Given this list of marker genes BLM, TMEM97, POP7, TUBB4B, DIO2, SPC25, PTPRF, CCNE1, IL7R, EXOSC8, MYBL1, SLC7A1, MELK, LPXN, PALM2AKAP2, POLR1E (RNA polymerase I subunit E), OGFRL1, CENPU, GINS2, FOXM1, MEST, THBS1, EFEMP1, CDC6, NRG1, EIF5, RAD54B, MCM4, RGS20, FAM111A, GPRC5A, P3H2, POLR3K, RFC4, ZWINT, OLR1, AMIGO2, CKS2, MT1X, AURKB, MAD2L1, CD44, ATAD2, MCM3, YWHAH, FST, CALM2, CCNE2, RRP7A, CD24, MYOF, DDAH1, EIF2S1, ZWILCH, DHFR, TIPIN (TIMELESS interacting protein), PRIM1, FHL2, CCDC86, CDC45 (NCBI Gene Id 8319), MCM7, MCM6, ORC1, DCTPP1, PBK, BIRC5, DNAJC9, SERPINB2, UGCG, SLC38A1, CDC42EP3, PNP, SLC7A5, GINS3, HJURP, TMPO, MCM5, FOSL1, MRTO4, CAV2, TRIP13, RAD54L, TPM1, OIP5, FANCI, SERPINE2, PEA15, RRAS2, MICAL2, RFTN1, PDSS1, ODC1, NXN, H2AX, TNFRSF12A, ITGBL1, AUNIP, CCNA2, E2F1, NCAPG2, GINS1, RFWD3, DKK1, GMNN, TNPO1, PLAU (NCBI Gene Id 95176), EXO1, PFKP, NAV3, CTPS1, BARD1, DTL, RAD51AP1, DKC1 (dyskerin pseudouridine synthase 1), LYPD1, DMD, FEN1, TMEM158, ASF1B, RRM2, UBE2C, PRPS1, TYMS, SHCBP1, CDC25A (cell division cycle 25A), MCM2, MCM10, STC2, E2F8, MET, KIF2C, CXCL8, DSCC1, USP1, TUBB6, SPDL1, CAV1, EGFR, ABHD5, CDK1, SH3BP4, NMT2, CRIM1, here is a description of the gene set: Human Gene Set: RUIZ_TNC_TARGETS_DN Genes down-regulated in T98G cells (glioblastoma) by TNC. from publication Ruiz C, Huang W, Hegi ME, Lange K, Hamou MF, Fluri E, Oakeley EJ, Chiquet-Ehrismann R, Orend G (PMID 15492259) species: Homo sapiens Tenascin-C is an adhesion-modulating extracellular matrix molecule that is highly expressed in tumor stroma and stimulates tumor cell proliferation. Adhesion of T98G glioblastoma cells to a fibronectin substratum is inhibited by tenascin-C. To address the mechanism of action, we performed a RNA expression analysis of T89G cells grown in the presence or absence of tenascin-C and found that tenascin-C down-regulates tropomyosin-1. Upon overexpression of tropomyosin-1, cell spreading on a fibronectin/tenascin-C substratum was restored, indicating that tenascin-C destabilizes actin stress fibers through down-regulation of tropomyosin-1. Tenascin-C also increased the expression of the endothelin receptor type A and stimulated the corresponding mitogen-activated protein kinase signaling pathway, which triggers extracellular signal-regulated kinase 1/2 phosphorylation and c-Fos expression. Tenascin-C additionally caused down-regulation of the Wnt inhibitor Dickkopf 1. In consequence, Wnt signaling was enhanced through stabilization of beta-catenin and stimulated the expression of the beta-catenin target Id2. Finally, our in vivo data derived from astrocytoma tissue arrays link increased tenascin-C and Id2 expression with high malignancy. Because increased endothelin and Wnt signaling, as well as reduced tropomyosin-1 expression, are closely linked to transformation and tumorigenesis, we suggest that tenascin-C specifically modulates these signaling pathways to enhance proliferation of glioma cells.